The following is a description of a gene set: Human Gene Set: MIR6842_3P from publication Chen Y, Wang X (PMID 31504780) Genes predicted to be targets of miRBase v22 microRNA hsa-miR-6842-3p in miRDB v6.0 with MirTarget v4 prediction scores > 80 (high confidence targets). species: Homo sapiens, and this is the list of marker genes: ZNF618, ST8SIA5, MTFR1L, CDKN2AIP, SOX12, RHOQ, SULF2, RANBP9, ASCC2, PCGF2, ASPH, RASGRF1, NECTIN1, TTBK1, SCIMP, RAPGEF5, ZNF316, ADGRL2, CYP21A2, SPATA31F3, SHROOM4, GRAMD1B, PCSK6, SH3KBP1, PHACTR4, MYL12A, RSPRY1, NAB1, TRIM40, TUT4, HSPB6, THAP5, RCC1L, RASGEF1A, AGO3, CELF4, AGO1, MAP2K7, ST6GALNAC6, ADCY1, MDM1 (Mdm1 nuclear protein), ERAP2, FAM168A, EAF1, UBR5, PTPRT, ARHGEF15, SDC3, MBD4, ZNF329, KLF6, SCN8A, PRR12, GSKIP, FLNA, VSTM2L, SMPD3, GUCD1, SELENON, CPEB2, SUSD6, PLPPR2, SLC44A1, DGAT2L6, MCUR1, SOX5, SLC1A1, RPP14, GPRC5C, SYT1, TRABD2B, SEMA6C, CDC42BPA, PLXNA4, ITGA8, ZNF7 (NCBI Gene Id 7553), PPP1CB, EFNB3, TBC1D16, NUAK1, OR2H1, COBL, FAM110B, SEZ6, MYEF2, CLOCK, DAOA, FTL, RERE, OSBP2, LYSMD4, XPO6, MAGI1, CEP350 (centrosomal protein 350), GLS, IREB2, MBD2, EFEMP1, SLC43A2, TEAD1, PLXNA2, STOM, PIK3AP1, EIF4A2, BCL11A, SRF, CCDC28A, TMEM248 (transmembrane protein 248), VCAN, TP53, CLSPN (claspin), TXLNB, ZDHHC7, DRC7, FAM222B, CBFA2T3, AHCYL2 (adenosylhomocysteinase like 2), ZDHHC14, KIAA0930, SIX3, MPI, CORO1C, GARRE1, PPP1R3B